The following is a description of a gene set: from publication El Kasmi KC, Holst J, Coffre M, Mielke L, de Pauw A, Lhocine N, Smith AM, Rutschman R, Kaushal D, Shen Y, Suda T, Donnelly RP, Myers MG Jr, Alexander W, Vignali DA, Watowich SS, Ernst M, Hilton DJ, Murray PJ (PMID 17114459) IL-10 or IL-6 stimulation of control 129xC57BL/6 murine bone marrow derived macrophages in the presence of LPS. We used microarrays to detail the global programme of gene expression changes in response to IL-6 or IL-10 stimulation in the presence of lipopolysaccharide. BMDMs were isolated from control, IL-6-/-, and IL-10-/- mice on a 129XBL/6 mixed background mice and differentiated in the presence of CSF-1 for 6-7 days. Cells were scraped and plated in 6 well plates at 2x10e6/well. Cells were washed with complete DMEM and rested for 1-2 hr before stimulation with combinations of IL-10 (10 ng/ml), IL-6 (2 ng/ml) or LPS (100 ng/ml) for 45 min or 180 mins. Complete biological replicates were performed. studied in species Homo sapiens Human Gene Set: GSE5589_IL6_KO_VS_IL10_KO_LPS_AND_IL10_STIM_MACROPHAGE_180MIN_DN Genes down-regulated in bone marrow-derived macrophagesat 180 min of stimulation by IL10 and LPS: IL6 knockout versus IL10 knockout., and this is the list of marker genes: ITGAM, PLEKHF1, ANGPTL6, ITFG2, SLC3A2, RNASE3, PFKP, TMEM158, ANGPTL3, FOS, AQP9, ERO1A, FAHD1, TTC39B, EXO5, RHOV, CHCHD10, UBQLN1, ADORA2B, SLC38A9, HSPA1L, RABGEF1, MTERF1, ATP8A2, TRAF5, MED13L, PTRH1, DPF2, EIF2B2, KCNJ14 (potassium inwardly rectifying channel subfamily J member 14), MTMR7, SH3KBP1, EMP2, TENM4, BCAT2, TCEAL7, USP36, ZNF341, TSPAN31, SRP72, RIC1, FNDC3A, ZC3H12A, N4BP1, SMIM6, ZBTB5, EDIL3, GALNT15, CDR2L, DMTF1, NIPA2, TMEM181, CCL24, MAP4K1, UTP25, RXYLT1, CASP6, ZPR1 (NCBI Gene Id 95155), HIBADH, UTP18, LAYN, GYPC, CYB5R1, CDK8, PGM5, TMEM11, RGS1, NTHL1, USP40, NDUFA13, LIMK1, MRI1, ITGA2B, THRA, APTX, APEX1, GHITM, GPBP1, HOXD10, CNTNAP2, GFRA2, AMZ1, ALDH1B1 (aldehyde dehydrogenase 1 family member B1), LMOD3, MCRIP2, COMTD1, FZD7, BCAP31, DLST, TRIB3, FAM110C, LGI3 (leucine rich repeat LGI family member 3), FICD, PRKCI, HSPA1B, SMAD2, PANK4, SRGN, SSR4, CDK2AP2, RARS1, ADD3, ATP13A1, IGSF3, TMEM126B, TDRD3, PTGES2, PDGFA, PKD2L1, RNF113A, LONP1, TTPAL, NAPEPLD, TRMT61A, METRNL, ADAMTS1, SRA1, HSPE1, SIPA1L1, DDX31, SRPX2, SDAD1, PLA2G2E, MAP6D1, TOM1L1, KLF10, RPL14, MEF2C, TMEM198 (transmembrane protein 198), PABPC1, AUH, PPP3R1, WWC1 (WW and C2 domain containing 1), TESC (tescalcin), CD36, PSTPIP1, ALK, ADPRH, MAMLD1, ZNF598, PTPN3, PDE4DIP, RABGGTB, EGR1, GFI1B, REL, RASSF8, C1GALT1C1, TGFBR3, SLC30A4, FYTTD1, ST7, GRAMD4, DCBLD2, ABCD2, GGCX, SLC1A5, PLA2G12A, SEL1L3, ACVRL1, RIPK2, HK2, USPL1, ABCD3, PPA2 (NCBI Gene Id 92033), VMP1, SNHG32, WDR74, USP4 (NCBI Gene Id 7375), ERRFI1, PTK2, ARL15, CFAP418, PKDCC, WNT5B, MAP4K5, SPIRE1, ACTN1, MCF2L, BST1, SERTAD1, SLC25A32, NARS1, AFG3L2, ENPP6, SNHG6, HNRNPH3, EMC4, MFHAS1, TFPI2, BSCL2, GTF3C4, PROKR1, IGF2BP3, TRNAU1AP, BAG5, PTPMT1, FSD2, DGKG, CLIC4